The following is a description of a gene set: Human Gene Set: GOCC_NEURONAL_DENSE_CORE_VESICLE_MEMBRANE The lipid bilayer surrounding a neuronal dense core vesicle. species: Homo sapiens, and this is the list of marker genes: STXBP5, CADPS, SYT5 (NCBI Gene Id 6861), SYT4, KIF1A